The following is a description of a gene set: Reactome Pathway: Resolution of D-loop Structures through Holliday Junction Intermediates electronically inferred by orthology from the curated human pathway This event has been computationally inferred from an event that has been demonstrated in another species.<p>The inference is based on the homology mapping from PANTHER. Briefly, reactions for which all involved PhysicalEntities (in input, output and catalyst) have a mapped orthologue/paralogue (for complexes at least 75% of components must have a mapping) are inferred to the other species. studied in species Mus musculus part of: Resolution of D-Loop Structures, and this is the list of marker genes: Top3a (NCBI Gene Id 21975), Wrn, Gen1, Dna2 (NCBI Gene Id 327762), Mre11a, Slx4, Rad51b, Kat5, Palb2 (NCBI Gene Id 233826), Fignl1, Bard1, Blm, Firrm, Brca1, Nbn, Xrcc3, Mus81, Rad51ap1, Slx1b, Rad51c, Brca2, Rbbp8